Given this list of marker genes MAP2K1, PRPSAP1, PAPSS1, ATP5MJ, NDUFC2, IL4, PARP1, PPARA, GUCA1A, NDUFC1, TMSB4X (NCBI Gene Id 7114), MT-ND3, PRPSAP2, ATP6V0C, PID1 (phosphotyrosine interaction domain containing 1), FAM3A, ADSL, NDUFS4, NDUFA11, ATP5MK, MT-ATP8, GUCY1A1, GART, NDUFB11, NMNAT1, ATIC, GUCY2D, LDHC, NDUFA12, PRPS1, NMNAT3, MT-ND6, PRKAG2, ATP5F1A, ADSS1, ATP5F1B, IDH2, ADCY6, ATP5MG, MTHFD2L, NADK, NDUFA2, QPRT, NDUFB10, NDUFB7, SLC4A7, ATP5F1E, ADCY8, NDUFA10, SDHA, NDUFV3, ATP5PB, PINK1, NAMPT, GUCY1A2, NADSYN1, NDUFA6, AMPD2, ADCY1, NME1, IDO2, NDUFS3, NMRK1, NME9, TREM2, NME2P1, NME4, NPPB, TAFAZZIN, NDUFB3, ADCY5, NADK2, PRPS1L1, ATP5MC2, NDUFB1, ADSS2, MTHFD1, APRT, ENO1, HPRT1, STAT3, ATP5MF (ATP synthase membrane subunit f), NDUFAB1, SDHC, DNAJC30, PRKN, NDUFS8, MT-ATP6, DMAC2L, NDUFB6 (NCBI Gene Id 4712), NME7, UQCC3, ATP5PF, NMNAT2 (nicotinamide nucleotide adenylyltransferase 2), NDUFS7, ATP5MC3, GUCY1B1, AK4, ADCY9, NDUFB8, NDUFA1 (NCBI Gene Id 4694), AMPD3, ADCY3, SDHB, MT-ND1, ATP5IF1, ATP5PO, ATP5F1C, NDUFA9, IDO1, GUCA1ANB-GUCA1A, SLC25A13, NDUFA13, ATP5PD, PPAT, MT-ND5, NPPC, KMO, GUK1, NDUFV2, DCK, NDUFB5, NMRK2, NDUFA7, NME5, ATP5F1EP2, ATP5MGL, NDUFV1, NME6, NDUFA8, PAICS, STOML2, ATP5F1D (NCBI Gene Id 513), NPR2, AK2, NDUFB2, ADCY10, NDUFS1, MT-ND2, NDUFB9, ATP5MC1, NDUFB4, GUCY2F, AK5, NUDT2, NPPA (NCBI Gene Id 90230), NDUFA3, NDUFS6, MT-ND4L, SPHK2, NDUFA5, ADCY7, AFMID, VPS9D1, LIPA, PRPS2, DGUOK, SDHD, GMPS, NDUFS5, PAPSS2, ADCY4, HAAO, ADCY2, AK3, NAPRT, TGFB1 (NCBI Gene Id 7040), ADA, MT-ND4, AK1, KYNU, ALDOA, IMPDH2, ATPSCKMT, ACMSD, LETMD1 (NCBI Gene Id 25875), RD3, IMPDH1, VCP, NDUFS2, NPR1, AMPD1, GUCY2C, ADK, NME3, ATP5ME, PFAS, ANTKMT, ASPDH, NME2, COX11, MIR675, here is a description of the gene set: Human Gene Set: GOBP_PURINE_NUCLEOTIDE_BIOSYNTHETIC_PROCESS studied in species Homo sapiens The chemical reactions and pathways resulting in the formation of a purine nucleotide, a compound consisting of nucleoside (a purine base linked to a deoxyribose or ribose sugar) esterified with a phosphate group at either the 3' or 5'-hydroxyl group of the sugar.